The following is a description of a gene set: The directed movement of a monoatomic ion into, out of or within a cell, or between cells, by means of some agent such as a transporter or pore. Monatomic ions (also called simple ions) are ions consisting of exactly one atom. Human Gene Set: GOBP_MONOATOMIC_ION_TRANSPORT species: Homo sapiens, and this is the list of marker genes: SCN3B (NCBI Gene Id 55800), ATP6V1C1, SLC12A8, FXYD6P3, NALCN, MT-ND1, CLCN3, PTPN3, SLC39A10, SLC6A13, FKBP4, KCNK3, SLC25A37, GRIK4, GRIN3A, SLC1A2 (solute carrier family 1 member 2), SLC23A2, ABCC3, CDKN1B, SLC39A12, KCNK4, STK39, CHRNA1, HCN3, SLC15A4, CD63, ANO10 (NCBI Gene Id 55129), TRPM4, GRIA4, COX7B, GABRR3, PDPK1, KCNJ6, TREM2, NOS3, CACNA1F, STIMATE, SLC10A2, KCNJ16, NIPAL2, STEAP4, SLC25A4 (solute carrier family 25 member 4), MCU, KCNJ14, STIM2, DHRS7C, ABCB8, NKAIN3, SLC30A5, FXYD6, SCN5A, KCNJ9, ITGAV, SLC4A5, SLC26A4, CTSS, COX6B1, CNNM1, TMC5, LILRA5, ATP6V0B, PLCL2, SELENOK, TMEM163, MIR192, GAL, CLIC6, ATP6AP2, TRPV6, ATP6V0D2, ATP6V0A4, CASR, MELTF, MIR103A1, LILRB2, BCL2, NOX5, KCNC3, SLC12A1 (NCBI Gene Id 6557), CACNB1, SLC22A5, BAX, GNB5, CYBRD1 (cytochrome b reductase 1), YWHAQ, CACNA1B, P2RY6, CDK2, FYN, STAC3, GABRE, MIR208A, MCHR1, ABCC8, TRPC1, PLLP, SLC17A3 (solute carrier family 17 member 3), NCS1, CCDC51, NDUFB10, AGT, FLVCR1, ATP11B, OSR1 (NCBI Gene Id 4955), ERO1A (endoplasmic reticulum oxidoreductase 1 alpha), WNK3 (WNK lysine deficient protein kinase 3), TACR2, CACNA1S, KCNRG, CNGA1, ATP2A2, IL16, KCNC1, PLCH2, PMPCB, ABCB1, SLC26A8, ATP5MGL, SLC39A4, SLC26A6, F2, STEAP3, CBARP, CD84, SERPINE2, RAMP1, MYLK, MFSD5, TMBIM6, SCN4B, MT-ND4L, GLRA2, HTR3B, TRPM2, FXYD2, KCNS2, ATP6V1A, KCNH2, LASP1, AP3D1, EPPIN, NDUFS1, MICU3, ABCC5, MLLT6, MYB, GABRA5, SURF1, GRIN3B, UBQLN1, PDE4D, CCL8, SLC17A4, AQP1, ATP13A4, KCNH7 (NCBI Gene Id 90134), CYBB, CLCN7, SLC6A12, SLC22A4, CCL4 (C-C motif chemokine ligand 4), FLVCR2, SLC17A8, GPR89A, VDAC1, PACSIN3, HTR2A, SLC12A5, CLIC2, NDFIP1, CXCL12, LILRA2, SLC6A15, PXK, SLC41A2, CTNNB1, EDN1, KCNAB2, CACNA1C, SLC26A2, CACNB4, CYBA, ABCC4, COX7A1, SLC9B1, ATP6V1C2 (NCBI Gene Id 245973), CHRNA9, EGF, CAPN3, SLC6A19 (solute carrier family 6 member 19), ASIC1, WWP1, TOR2A, HCN4, TMEM175, ASIC2, CHRNA2, CALHM5, FTL, SLC30A1 (NCBI Gene Id 7779), DPP6, CLCNKB, ANK2, SLC6A11, CLCC1, KCNJ8, RYR2, SLC15A1, PACC1, GNB2, SLC4A11, ITGB3, CXCL10, CRBN, CLCNKA, HSPA9, ATP1B4, TRPM1, SLC4A1 (solute carrier family 4 member 1 (Diego blood group)), SLC5A1, IL13 (interleukin 13), NDUFB7, KCNH3, GABRG1, ASIC5, OTOP1, KCNE2, HAP1, FKBP1A, ABCC9, ATP2C1, CHRNB4, ABCC6, REM1, SLC25A1, KCNH1 (potassium voltage-gated channel subfamily H member 1), NDUFS7, PLA2G1B, TPCN2, CNNM3, GABRD, HPN, SRL, NKX2-5, KCNT1, MIR328, SLC4A9, ATP10A, LRRC8E, DRD3, KCNG1, SNAP25, SLC6A5, NIPAL3, SLC6A18, HEPH, KCNAB1, CNKSR3, PLCL1, SCN4A, THY1 (NCBI Gene Id 94105), CNGB1, MCOLN1, DIAPH1, SLC2A10, SLC22A15, PRKG2, PRKCB, GRIN2D, TGFB1, GPR89B, ATP5F1D, ANO4, GALR2, NDUFS5, CHRNA5, CBLIF, SLC9A9, GPR35, GRIN2C, PANX1, GJC1 (NCBI Gene Id 10052), CCL21, NDUFB8, OSTM1, ATP5PB, SLC47A2, MIR424, BDKRB1, ATP5F1B, NIPAL4, CORO1A, ATP6V1D, CHRNA3, ORAI1, SLC13A4, PER1, MFSD4B, CA2, ASPH, LRRC55, LRRC26, CAMK2D, KCNMB2, SLC22A31, SLC24A4, PTK2B, CHRNG, KCNIP1, MIR26A1, LRRC8A, SLC30A4, ATP5PD, GABRP, P2RY4, SLC9C1, LRRC8B (leucine rich repeat containing 8 VRAC subunit B), SHOC2, ATPSCKMT, TRPV4, SUMO1, SEC61A1, ROMO1, KCNA3, PKD1L3, NDFIP2, TRPV2, ATP13A1, CLCN4, FLNA, NDUFB9, UNC80, GRID2, TRPC4AP, ATP5MC3, MIR200C, MIR21, CHRFAM7A, KCNN2 (potassium calcium-activated channel subfamily N member 2), CASQ1, PIK3CG, TRPC3, SLC22A11, SLC10A4, FGF13, ATP2B1, SLC22A8, KCNG3, SCN8A, TRPV5, ANK3, NDUFC1, NEDD4 (NEDD4 E3 ubiquitin protein ligase), SLC5A2, TMEM150C, KCNK15, TMC7, TMC1, TPTE2, KCNA10, SLC23A1, P2RX6, ATP6V0A1, PDE4B, MT-ND6, SLC10A7, NDUFB6, GCK, PKD1L2, CCL2, ADORA1 (NCBI Gene Id 134), KCNK9, SLC26A5, KCNJ5, BPIFA1, ATP1A4, GSTO1, SLC9A6, SCN10A, FTHL17, SHROOM2, TMC8, TTYH2, ATP5PO, VAMP2, APLNR, CHRNE, PPP3R1, KCNJ2, NDUFA12, SLCO4C1, KCNA5 (NCBI Gene Id 3741), ISCU, ABCC10, SLC24A1, TRPM8, SEMG1, CALCRL, ASIC4, CALM3, BEST2, UCP3, KCNJ12, AMIGO1, SLC9B1P1, UBR3, LMTK2, CAMK2B, SLC24A5, ORAI2, SMDT1, P2RX3, CREB3, SLC38A7, ATP5MG, SLC25A18, PANX2, PKD2L2, ATP1B2, CLDN16, HEPHL1, KCNH6, ATP2C2, CACNA1I, HTR3E, HOMER1, GRM6, CLDN17, GJA5, LACRT, GABRG2, HTT, P2RY12, RAB11B, SLC39A13, SLC10A5, TCIRG1, SLC47A1, MIR1-1, KCNJ4, SELENON, NDUFS8, COX5A, SLC39A2, P2RX7, GP1BB, HVCN1, ATP13A5, GLRB, SLC39A5 (NCBI Gene Id 378941), KCNB1, CLDN10, ATP6V1F, SLC5A8, SLC8A1, PPP3CB, GOPC, STOM, SLC5A5, HAMP, ATP5F1E, SPTBN4, CLDN15, NDUFA8 (NCBI Gene Id 4702), RCVRN, PLCG2, ASIC3, SLC6A16, INPP5K, MRS2, ATP2B4, RNASEK, CLCN5, AKAP7, WFS1, P2RX5, TOMM40L, KCNE4, CYP27B1, ATP1B1, ATP10D, TG, SLC22A6, PLCB4, SLC26A11, LGALS3 (galectin 3), STEAP2, NMUR2, KCNK10, MRLN, NIPSNAP2, KCNN4 (potassium calcium-activated channel subfamily N member 4), GRIK3, TMEM37, COX17, NDUFV2, CUTC, NMUR1, AHCYL1, RAMP3, SLC2A9, DRD2, HTR2B, ATP2A3, PTPN6 (protein tyrosine phosphatase non-receptor type 6), EDNRA, ADORA2A, SLC36A2, ATP8B2, TPCN1, F2RL3, EFHB, CALCA, DRD1, GABRB3, SCN3A, CHRM1, MIR210, NEDD4L, LRP2, MMP9 (NCBI Gene Id 4318), GRIK5, PIEZO2, IFNG, HTR3A, SLC9A7, SLC26A7, FMR1, GABRQ, TMSB4X, PLCB2, BIN1, WNK4, MIR24-1, PRNP, UQCRH, SCNN1G, ATP6V0C, KCNS3 (NCBI Gene Id 3790), ATP8A1, SLC29A4, MAIP1, CACNA1A, SPG7, SLC6A1, KCNQ2, TCN2, PPIF, CLCN1, GABRA4, SLCO2B1, GLRA3, SLC46A3, CHRNA6, CALHM1, NHERF4, LRRC52, NDUFB1, CNGA4, MT-ATP6, SLC9A1, ANO7, G6PD, SPHK2, SLC38A11, LPAR3, KCNJ15, YWHAE, ATP6V0E1, CUL5, NDUFA5, CNTN1, CRHR1, EDNRB, SLC17A7, TSPAN13, KCNQ5, KCND3, ARHGAP1, GRINA, ATP2A1, SLC6A20, TMCO3, CTNS, SLC30A7 (solute carrier family 30 member 7), SLC35G1, FAIM2, ATP13A2, KCNIP2, SLC6A3, SLC22A1, COMMD9, CLCA1, VDR (NCBI Gene Id 7421), SCN11A, NDUFV3, CYSLTR1, GAS6, SLC4A3 (solute carrier family 4 member 3), PKD1L1, SPG11, CACNA2D2, SNCA, UQCRFS1P1, SLC12A9, ATP5MF, NDUFB3, NECTIN1, CCT8L2, GABRA1, ISL1, SLC18A1, TFRC, SRI, CACNG7, SLC22A20P, FTH1, NOL3, SLCO1B1, CACNA1H, KEL, CACNA2D4, CD19, TMEM63A, SLC39A6, CAMK2G, LHFPL5, GHITM, ZDHHC13, KCNMB3 (NCBI Gene Id 27094), ATP6V1G3, KCNE1 (NCBI Gene Id 3753), PLCZ1, GRIA3, FKBP1B, ABCB7, NALF2, CLCA2, TUSC3 (NCBI Gene Id 7991), STRIT1, NIPAL1, MIR208B, CALHM3 (NCBI Gene Id 119395), TMEM94, SLC11A1, UTRN, ABCC2, B2M, EPO, GLRA1, KCNH4, YWHAH, CACNA1E, SLC34A1, GABRA6, SLC5A6, SLC30A6, EPB41, KCNJ13, LILRB1, SLC34A2, PLCB1, CLIC1, XCL1, KCNE3, PRKACA, ANXA6, GRP, SLC18A2, GRXCR1, SLC17A2, PPP3CC, CX3CL1, SLC12A2, WWP2, SLC22A12, CAV3, SLC48A1, GABRG3, MT-ND3, NALF1, TCAF2, ANO5, GCG, SFXN3, RGS4, SLCO4A1, ATP6V0A2, STING1, KCNA2, ADCYAP1R1, TSC1, TRIM27, CACNG1, NDUFS6, KCNK6, GPM6A (NCBI Gene Id 2823), SLC9A8, SLC9A4, GABRA2, KCNJ18, KCNAB3, DDIT3, VDAC2, KCNG2, SLC6A17, SLC4A7, MIR29B1, AHNAK, SLC31A2, RANGRF, NDUFA1, KCNK18, ABCC11, CXCL9, NKAIN4, ATP1A3, SLMAP, CLIC3, ACTN4, ATP6V1B1, SLC20A2, GP5, CCL5, SLC4A8, KCND2 (NCBI Gene Id 3751), METTL21C, SLC5A11, ATP8B1, NDUFB2, SLC38A2, SLC8A3, TPTE, SLC30A10, KCNE5, KCNV2, SLC18A3, MT-ND5, TFR2, ATP5F1C, CALHM2, ZMPSTE24, FXYD7, BSND, MT-CO2, MMGT1, GRIA1, SCN7A, SLC11A2, SLC25A27, OCA2, PRKD1, KCNA7, ATP5MC2, SLC17A1, HTR3D, SLC5A9, CLDN4, SLC25A26, LEP, CRACR2A, SLC6A7 (solute carrier family 6 member 7), KCND1, CACNG8, SLCO1A2, GP1BA, DMD, KCNK12, KCNK16, ATP11C, DNM1L, NDUFA10, PPP3R2, KCNIP3, SLC39A7, FTH1P19, NOS1AP, ATG5, CCR5, IBTK (inhibitor of Bruton tyrosine kinase), ATP1A1, SLC5A4, KCNU1, JPH4, CAV1, JPH3 (junctophilin 3), MT-ATP8, TRPC7, VPS4B, NHERF1 (NHERF family PDZ scaffold protein 1), CNGB3, LRRC8C, TMEM63B, UMOD, CACNA1D, GRIN2A, GRIK2, SCN1B, OTOP2, ATP1A2, SLC38A5, TOMM40 (NCBI Gene Id 10452), SLC25A3, CCR1, AKT1, GABRB2, CHRND, SLC12A6, SLC32A1, SLC25A14 (solute carrier family 25 member 14), BHLHA15 (NCBI Gene Id 168620), PLCG1, SLC10A6, APP, NGF, CHRNB1, KCNIP4, SLC3A2, AKAP5, SLC25A28, CLIC4, NDUFS4, CHRNB2, CRH, WNK1, SARAF, SFXN1, SLC6A4, LCN2, FXYD5, MIR499A, FXYD3, STIM1, MT-ND2, APOL1, TRPA1, ABCC1, MT-ND4, TTYH1, HRC, CALHM6, EDN3, MCUR1, SLC24A3, HTR1A, ANO6, SLC25A5, GABRA3, MCUB, NDUFA6, SLCO1C1, NSF, CHRNB3, TMC2, HTR2C, SLC38A4, ATP5F1EP2, ATP5PF, P2RX2, CAMK2A, BAK1, SFXN2, MTCO2P12, HPCA, SLC26A10P, SLC39A14, KCNN1, CCL19, CCR7, KCNK2, TMBIM1, GUCA2B, NDUFA2, GABRR2, CACNG2, ANO2, ATF4, DPP10, CACNA2D1, CHRNA7, SLC22A2, SLC5A12, SIK1, CA7, SLC26A9, FTMT, PLCB3, SLC4A10, CALM2, NDUFB4, CDK5, NDUFV1, KLHL3, SLC40A1, SLC38A1, MFSD8, ATP6AP1, F2R (coagulation factor II thrombin receptor), SLC41A3, SLC31A1 (solute carrier family 31 member 1), P2RY1, ATP5ME, SCN2B, JPH1, GJD3, CATSPER1, JPH2, PLN, KCNK5, CATSPER3, NDUFS3, MAGED2, CHERP, ORAI3, PDGFRB, TRPV3, CRACR2B, KCNA4, KCNK7, BEST3, SLC19A1, KCNC2, TRPC4, MIR93, ANO1 (NCBI Gene Id 55107), CYC1 (NCBI Gene Id 1537), KCNS1, SLC5A10, SFXN5, MIR133A1 (microRNA 133a-1), CACNB2, SLC46A1, KCNQ4, CNNM2, SLC25A23, MT-CO3, NDUFS2, SLC4A2, TMBIM4, SLC13A1, UQCRC1 (NCBI Gene Id 7384), SLC8A2, CATSPER2, COX7A2L, MCOLN2 (NCBI Gene Id 255231), KCNH8, CCL3, NDUFB5, KCNA1, CACNA2D3, TRPM3, SLC38A3, MIR448, CSN2, MICU2, UQCRFS1, COX5B, GRIN1 (glutamate ionotropic receptor NMDA type subunit 1), LRRC8D, PPP3CA, STC2, SLC39A8, GPD1L (NCBI Gene Id 23171), ATOX1, GRID1, SLC36A3, KCNQ1, TRPM5, FGF12, ACTN2, FASLG, ITPR2, COMMD3, VMP1, GRAMD2A, PKP2, NDUFA7, PLPP4, SPINK1, PKD1, GRIA2, SLC41A1, ANO9 (NCBI Gene Id 338440), ANO8, ATP13A3, RACGAP1, ATP6V1G1, STC1, TMX1, TMC4, SLC25A10, SLC26A3, CACNG6, ZACN, GABRR1, SLN, CFTR, NDUFA3, GNAI2, ATP2B2, KCNMA1, TMCO1, ATP7B, HCN1, CHRNA4, FXYD4 (FXYD domain containing ion transport regulator 4), SCN9A, RYR3, SLC6A6, CLCA4, ATP1B3, TMEM63C, COX4I1, HCRT, TESC, ATP2B3, PKD2, TMEM38A, FHL1, KCNF1, KCNG4, LTF, KCNV1, KCNK17, SLC25A12, KCNK13, KCNQ3, SLC9A3, NTSR1, HPX, REP15, HOMER3, SLC13A2, PKD2L1, MIR34A, CACHD1, NOS1, DNM2, ATP6V1G2, UCN, PSEN2, LYN, SLC25A22, ATP6V1H, XCR1, DLG1, SLC8B1, ATP4A, CNGA2, MT-CO1, KCNA6, RAMP2 (receptor activity modifying protein 2), SLC12A7, LIME1, NKAIN2, SLC1A6, PRKCE, SLC34A3, SLC22A18, CASK, P2RX1, SESTD1, SLC1A3, SCN2A, CLTC, COMMD1, BEST4, CACNG5, ANO3, NIPA2, CASQ2 (NCBI Gene Id 845), SLC30A2, AQP11, FFAR1, CXCR3, PML, UCP1, TF, SLCO3A1, SLC4A4, SLC13A3, SFXN4, PRSS8, CLCN2, SLC20A1, VDAC3, TRPM7, PSEN1 (presenilin 1), SLC1A4, PTPRC, LARGE1, SLC12A3, HFE, SLC1A1, RYR1, AQP6, CNGA3, SLC9A2, CLNS1A, SLC22A3, FXYD1, GSTM2, PLCE1, ITPR3, LCK, BSPRY, TTYH3 (NCBI Gene Id 80727), TLR9, TRPV1, ADRB2, NDUFA4, KCNMB1, SLC22A23, ATP6V0E2, SLC5A3, CACNB3, NIPA1, TPT1, OPRM1, GRIN2B (NCBI Gene Id 2904), CATSPER4, SLC18B1 (solute carrier family 18 member B1), NDUFC2, KCNJ1, NDUFA9 (NCBI Gene Id 4721), KCNB2, NPSR1, TMEM120A, SGK1, SLC22A17, SLC10A1, SCARA5, HES1, DCD, CNNM4, GP9 (NCBI Gene Id 2815), PON3, CAB39 (NCBI Gene Id 51719), NKAIN1, ITPR1, KIF5B, WNT3A, SLC25A25, LETM1, ATP6V1B2 (ATPase H+ transporting V1 subunit B2), CLIC5, HTR1B, TRPM6, SNTA1, SLC12A4, SCNN1D, OPRK1, ABL1, ATP4B, CHRNA10, PIEZO1, ITPRIPL1, ATP6V0D1, UCP2, SCN1A (sodium voltage-gated channel alpha subunit 1), PDGFB, FCRL3, GPER1, MT3, LETM2, CXCL11, SLCO1B3, CD4, MT-CYB, ATP6V1E2, PLCH1, FXN, AFG3L2, SLC15A3, SLC6A14, WNK2, SLC39A11, SLC39A9, SCNN1A, SLC9A5, DMAC2L, OPRD1, PHB2, KCNJ10, TMEM109, SLC30A9, MS4A1, SLC26A1, AKAP6, KCNK1, CACNG4, PGRMC2, UBASH3B, KCNJ3, FGF2, BEST1, SLC17A6, SLC39A3, TRPC5, SLC1A7, P2RX4, TCAF1, EPM2A, SLC15A2, SCNN1B, HCN2 (NCBI Gene Id 610), NPPA, MIR212, TRDN, SLC22A16, DMPK, CEMIP, KCNT2, SLC13A5, NNT, MIR30D (microRNA 30d), SLC16A1, RGS9, CHP1, KCNMB4, SLC9C2, TMC3, ADRA2A, PDZK1, TMC6, PKDREJ, PLP2, ATP5MC1, LRRC38, GABRB1, SLC6A2, KCNH5, SLC6A9, SLC36A1, CDH23, SLC9B2, CHD7, CACNA1G, TRPC6, ATP12A, SLC24A2, MAGT1, STAC, SLC22A24, UQCR10, SLC30A3, ABCB6, OXSR1, TCN1, TMEM165 (transmembrane protein 165), HOMER2, MCOLN3, STAC2, ATP6V1E1, MICU1, CLCN6 (NCBI Gene Id 1185), GRIK1, SLC22A7, HTR3C, KCNN3, CALM1, PANX3, KCNJ11, SLC30A8, ATP7A, KCNC4, SLC17A5, SLC5A7, CALHM4, TSPO, SLC25A13, CACNG3, COX8A, SLC28A3 (NCBI Gene Id 64078), TMEM38B, PCSK9, OTOP3, ATP5F1A, SLC6A8, S100A6, GJA1, SLC39A1